Given this list of marker genes Itga1, Cd99l2, Ccl25, Cnn2, Slamf8, Lbp, Rarres2, Itga9, Ccl3, Cd47, Ppia, Msmp, Pawr, Ccl27a, Pde4d, Rac2, Slamf1, Ifng (NCBI Gene Id 15978), Trim55, Ccl19-ps3, Ror2, Plcb1, Abr (NCBI Gene Id 11357), Cxcl10, Fpr-rs7, Cxadr, Ccr2, Dapk2 (NCBI Gene Id 13143), Tnfaip6, Il1r1, Ptpro, Lgals3, Ptprj, Lyst, Swap70, Cyp19a1, Umod, P2rx4, Xcl1 (NCBI Gene Id 98422), Ccl1, Cxcl3, Ccl28, Ptger4, Bst1, Fpr-rs6, Akirin1, Fut4, Ccl2, Cxcl12, Ccl19, Ccr1l1, Ccl7, Selenok, Emp2, Il17ra, Trem3, Adam8, Nup85, Creb3 (cAMP responsive element binding protein 3), Ccl21a (C-C motif chemokine ligand 21 (serine)), Srp54a, Itgb2l, Lgmn, Ccr3, Ccl19-ps1, Scg2, Pikfyve, Il23a, Il34, Cxcl9, Mcoln2, Csf3r, Csf1, Ccl4, Camk1d, Fpr2, Ccl21d, Cd300a, Cx3cr1, Cxcl17, Defb25, Ccl24 (C-C motif chemokine ligand 24), Pgf, Ccl12, Dpp4, Dnm1l, Cd200r1, Anxa1, Enpp1, Thbs4, Mtus1, Ccl22, Edn1, Prkca, Stat5b, Ccl19-ps5, Pik3r1, Mcu, Ppib, Jagn1, Flt1, P2ry12, Il1b, Ccl26, Ccl21e, Mmp2, Il17b, B4galt1, Mmp9, Tnfsf18, Syk, Cxcl2, Il4, Pdgfb, Bcr, Nod2, Ppbp, Stap1, Itgam, Cd9, Cxcl13, Tafa4, C1qbp, Pdgfd, Rabgef1, Pecam1, Zpld2, Hc (hemolytic complement), Trpv4, Ccr7, Ager, Bsg, Pafah1b1, Rps19, Cxcl15, Sell, Kit, Myd88, Mmp28, Rin3, Cd200, Dusp1, Pla2g7, Trem2, Cxcl1, Vav3, Ccl21f, Ptger3, Trem1, Nf1, Dysf, Cd81, Retnlg, Mst1, Nbl1, Tgfb2, Serpine1, Lyn, Vegfa, Csf1r, Cxcr2, Spi1, Ninj1, Gbf1, C3ar1, Mospd2, Ccl11, Tirap, Fut7, App, C5ar2, Slit2, Ccn3, Mapk1, Ednra, Aif1, Sirpa, Chga (NCBI Gene Id 12652), Fpr-rs4, Fcer1g, Vav1, Cxcr1, Gm5849, Cmklr1, Arhgef5, Cxcl5, Rpl13a, Grem1, Vegfd, Fam3d, Wdr1, Ripor2, Gp2, Mstn, Hmgb1, Prtn3, Il1a, Vegfc, Vegfb, Pf4, Pde4b, Edn2, Cx3cl1, Il17a, Tlr2, Fpr-rs3, Mmp14, Jaml, S100a9, Fcgr3, Ccl5, Spp1, Thbs1, Dpep1, Ano6, S100a14, Epx, Il17rc, Ptk2, Ednrb, Rac3, Irak4, Prex1, Nckap1l, Myo9b, Mif, Ccr1, Rtn4, Kitl, Cd74, Itgb2, Rac1, Edn3, C5ar1, S100a8, Ptk2b, Cklf, Cd177, Ccl21b, Mpp1, Ccl19-ps6, Ccl8, Mdk, Slc37a4, Perp, Gpr35, Ctsg, Myo1f, Ccl19-ps4, Emilin1, Mapk3, Tnfsf11, Jam3, here is a description of the gene set: The movement of a myeloid leukocyte within or between different tissues and organs of the body. studied in species Mus musculus Mouse Gene Set: GOBP_MYELOID_LEUKOCYTE_MIGRATION